Given this list of marker genes Pdgfra, Tnf, Wnt2b, Ctnnb1, Sox9, Wnt2, Bmp4, here is a description of the gene set: species: Mus musculus Any process that modulates the rate, frequency, or extent of the process in which a highly ordered sequence of patterning events generates the branched structures of the lung, consisting of reiterated combinations of bud outgrowth, elongation, and dichotomous subdivision of terminal units. Mouse Gene Set: GOBP_REGULATION_OF_BRANCHING_INVOLVED_IN_LUNG_MORPHOGENESIS